Given this list of marker genes SLC9B2, SERF2, STOM, ZNF610, MFSD6, MAML3, KLHL24, PDCD4, LINC00667, SCG5, LINC00467, TM7SF2, PBLD, USE1, RNF170, FZD7, GALNT11, MYT1 (myelin transcription factor 1), NT5E, FGF7, LINC01003, PPCS, MC4R, LNP1, MBLAC2, CTNNA2, PAH, LINC00847, H4C8, LRRTM2, EIF5A2, NRSN1, RGS2, THNSL1, CLPB (ClpB family mitochondrial disaggregase), ZNF783 (NCBI Gene Id 100290062), TRAPPC2, TMEM17, ATP6V0E1, ZFP28, CPNE3, C12orf76, TMEM204, H2BC21, KLHDC1, TIGD1, RBMS3, H2AJ, ARMCX1, KDM6B, CPEB1, ZNF462, STARD4, UTRN, ZNF423, RUFY3, ENPP2 (ectonucleotide pyrophosphatase/phosphodiesterase 2), C7, TP53INP1, SATB1, BRWD1, LIN7B, MAGI2, LCORL, TBCK, SERINC3, TMEM219, CCDC32, here is a description of the gene set: from publication Molenaar JJ, Ebus ME, Koster J, van Sluis P, van Noesel CJ, Versteeg R, Caron HN (PMID 18413728) Genomic aberrations of Cyclin D1 (CCND1), CDK4, and CDK6 in neuroblastoma indicate that dysregulation of the G(1) entry checkpoint is an important cell cycle aberration in this pediatric tumor. Here, we report that analysis of Affymetrix expression data of primary neuroblastic tumors shows an extensive overexpression of Cyclin D1, which correlates with histologic subgroups. Immunohistochemical analysis showed overexpression of Cyclin D1 in neuroblasts and low Cyclin D1 expression in all cell types in ganglioneuroma. This suggests an involvement of G(1)-regulating genes in neuronal differentiation processes which we further evaluated using RNA interference against Cyclin D1 and its kinase partners CDK4 and CDK6 in several neuroblastoma cell lines. The Cyclin D1 and CDK4 knockdown resulted in pRb pathway inhibition as shown by an almost complete disappearance of CDK4/CDK6-specific pRb phosphorylation, reduction of E2F transcriptional activity, and a decrease of Cyclin A protein levels. Phenotype analysis showed a significant reduction in cell proliferation, a G(1)-specific cell cycle arrest, and, moreover, an extensive neuronal differentiation. Affymetrix microarray profiling of small interfering RNA-treated cells revealed a shift in expression profile toward a neuronal phenotype. Several new potential downstream players are identified. We conclude that neuroblastoma functionally depend on overexpression of G(1)-regulating genes to maintain their undifferentiated phenotype. Genes commonly up-regulated in SK-N-BE cells (neuroblastoma) after RNAi knockdown of CCND1 and CDK4. studied in species Homo sapiens Human Gene Set: MOLENAAR_TARGETS_OF_CCND1_AND_CDK4_UP